The following is a description of a gene set: species: Homo sapiens part of: Metabolism of porphyrins Reactome Pathway: Heme degradation Most of the heme degraded in humans comes from hemoglobin. Approximately 6-8 grams of hemoglobin is degraded daily which is equivalent to approximately 300 milligrams of heme per day. Heme is not recycled so it must be degraded and excreted. The iron, however, is conserved. There are two steps to heme degradation;<br>1. cleavage of the heme ring by a microsomal heme oxygenase producing biliverdin<br>2. biliverdin is reduced to bilirubin.<br>Bilirubin can then be conjugated with glucuronic acid and excreted., and this is the list of marker genes: ALB, ABCC1, UGT1A4, ABCG2, BLVRB, HMOX1, SLCO1B3, FABP1, HMOX2, SLCO2B1, ABCC2, BLVRA (biliverdin reductase A), GSTA1, UGT1A1, SLCO1B1, GUSB